The following is a description of a gene set: species: Mus musculus Mouse Gene Set: GOBP_POSITIVE_REGULATION_OF_MESENCHYMAL_STEM_CELL_DIFFERENTIATION Any process that activates or increases the frequency, rate or extent of mesenchymal stem cell differentiation., and this is the list of marker genes: Sox5, Nr6a1, Sox9, Ltbp3, Sox6